The following is a description of a gene set: Human Gene Set: GOBP_RIBOSOME_ASSOCIATED_UBIQUITIN_DEPENDENT_PROTEIN_CATABOLIC_PROCESS species: Homo sapiens The chemical reactions and pathways resulting in the breakdown of a protein or peptide encoded by an aberrant message and associated with a stalled ribosome. Degradation is initiated by the covalent attachment of a ubiquitin group, or multiple ubiquitin groups, to the ribosome-associated protein., and this is the list of marker genes: LTN1, TRIP4, ASCC2, RNF10, ASCC3, ZNF598, NEMF